Given this list of marker genes MOGS, GANC, GAA, MGAM2, MGAM, AGL, GANAB, SI, here is a description of the gene set: Catalysis of the hydrolysis of terminal, non-reducing alpha-linked alpha-D-glucose residue with release of alpha-D-glucose. studied in species Homo sapiens Human Gene Set: GOMF_ALPHA_GLUCOSIDASE_ACTIVITY